The following is a description of a gene set: Directly binding to a specific ion or molecule and delivering it either to an acceptor molecule or to a specific location. species: Homo sapiens Human Gene Set: GOMF_MOLECULAR_CARRIER_ACTIVITY, and this is the list of marker genes: HIKESHI, COX17, PTMA, EMC4, MTRR, HBM, TNPO3, ATP7A, EMC9, HBG2, EMC7, EMC8, RBP4, CALR, ISCU, GET4, DPH3, ANP32E, IPO11, RBP2, EMC2, NUP42, BAG6, NUP214, COX18, NUTF2, URM1 (NCBI Gene Id 81605), KPNA5, XPO6, JDP2, STARD7, CD14, CCS, CYGB, KPNB1, HBE1, MB, SPTY2D1, KPNA3, DUSP16, SCO2, RANBP17, XPO7, TNPO1 (NCBI Gene Id 3842), ASF1A (anti-silencing function 1A histone chaperone), HBG1, RANBP6, SCO1, CBLIF, HBA1, MMAA, NUBPL, EMC3, ASF1B, TF, PEX19, MMADHC, NDUFAB1, KPNA7, NUBP2, HBA2, KPNA1, EMC6, VPS72, SNUPN, MYD88, ZNG1E, XPO1, NGB, HBB, HSPA8, OXA1L, RAN, CLU, NUBP1, ANKRD13C, BAG3, TMCO6, PWP1, HBD, IPCEF1, WFS1, TIMM10, IPO4, TIMM9, KPNA6, WRAP53, HBZ, MTCH2, NAP1L1, KPNA4, TNPO2 (NCBI Gene Id 80048), TCN2, HIRIP3, MTCH1, IPO5, MMGT1, FXN, CSE1L, APLF, XPO4, ATOX1, PEX5, PARK7, DISP1, EMC10, PRDM12, HBQ1, XPO5, SERPINA6, IPO9, EIF4ENIF1, NFS1, GET3, EMC1, KPNA2